Given this list of marker genes Cd40lg, Col1a1, Lamc2, Il4ra, Thbs1, Lamb2, Tnfrsf1b, Il5, Cd86, Vtn, Col3a1, Il2ra, Zap70, Tnfrsf1a, Il2rb, Cd28, Ifng, Thbs3, Fn1, Lamc1, Lama5, Cd80, Il2, Lamb1, Col1a2, Il2rg, Cd40, Lck, Il4, Il5ra, here is a description of the gene set: species: Mus musculus Mouse Gene Set: WP_INFLAMMATORY_RESPONSE_PATHWAY Inflammatory response pathway